Given this list of marker genes Large1, Cacna1h, Myf6, Cdh13, Speg, Cd36, Fhl1, Myl7, Prnp, Sod3, Myh4, Gpx3, Reep1, Clu, Ptp4a3, Igfbp7, Pygm, Cdkn1a, Sgcg, Mybph, Cfd, Myh9, Nos1, Rb1, Ablim1, Hbegf, Col3a1, Col6a3, Cnn3, Dtna, Gadd45b, Bag1, Ache, Pgam2, Stc2, Tpm3, Ptgis, Hrc, Sorbs3, Myo1c, Actc1, Ifrd1, Ncam1, Myom2 (myomesin 2), Myl6b, Nqo1, Myl1, Bhlhe40, Ckb, Gaa, Myl4, Myog, Dapk2, Klf5, Eno3, Rit1, Myl2, Efs, Tsc2, Sh3bgr, Ckm, Psen2, Chrng, Agrn, Myh2, Smtn, Fxyd1, Cav3, Actn2, Csrp3, Tnnc2, Gja5, Slc6a8, Tnni2, Plxnb2, Tcap, Notch1, Cryab, Mef2a, Pdlim7, Myl3, Col1a1, Myh8, Mapre3, Atp6ap1, Erbb3, Tagln, Adam12, Pcx, Ldb3 (LIM domain binding 3), Col4a2, Dmd, Itgb4, Casq1, Sln, Actn3 (actinin alpha 3), Sparc, Mylpf, Ctf1, Myh1, Ak1, Tnnt1, Cox6a2 (cytochrome c oxidase subunit 6A2), Ppp1r3c, Myoz1, Chrna1, Ckmt2, Bin1, Acta1 (actin alpha 1, skeletal muscle), Itgb1, Pvalb, Foxo4, Eif4a2, Cacng1, Kcnh1, Ankrd2, Crat (NCBI Gene Id 99316), Itgb5, Itga7, Acsl1, Mylk, Des, Mapk12, Pde4dip, Tpm2, Fabp3, Tpd52l1, Chrnb1, Kifc3, Aebp1, Dmpk, Col15a1, Tead4, Atp2a1, Aplnr, Tnnt3, Pkia (NCBI Gene Id 99614), Cox7a1, Svil, Schip1, Apod, Syngr2 (NCBI Gene Id 20973), Dennd2b, Ryr1, App, Spdef, Vipr1, Fkbp1b, Nav2, Kcnh2, Gabarapl2 (NCBI Gene Id 93739), Hdac5, Flii, Wwtr1, Bdkrb2, Myh11, Ephb3, Tnnt2, Tgfb1, Sirt2, Mef2c, Col6a2, Mras, Myom1, Mb, Sgca, Myh3, Camk2b, Fgf2, Igfbp3, Myh7, Pfkm, Gsn, Fst, Mybpc3, Mef2d, Tnni1, Tnnc1, Sspn, Fdps, Hspb8, Lpin1, Pick1, Sphk1, Sh2b1, Sgcd, Hspb2, Akt2, Sptan1, Adcy9, Agl, Casq2, Lama2, Ocel1, Gnao1, Igf1, Ppfia4, Lsp1, Sorbs1, here is a description of the gene set: Mouse Gene Set: HALLMARK_MYOGENESIS Mouse genes annotated to HALLMARK_MYOGENESIS based on orthology mappings provided by the Alliance Genome Consortium studied in species Mus musculus from publication Howe DG, Blake JA, Bradford YM, Bult CJ, Calvi BR, Engel SR, Kadin JA, Kaufman TC, Kishore R, Laulederkind SJF, Lewis SE, Moxon SAT, Richardson JE, Smith C (PMID 30224793)